The following is a description of a gene set: studied in species Mus musculus Any process that modulates the frequency, rate, or extent of the self-propelled movement of a cell or organism from one location to another in a behavioral context; the aspect of locomotory behavior having to do with movement. Mouse Gene Set: GOBP_REGULATION_OF_LOCOMOTION_INVOLVED_IN_LOCOMOTORY_BEHAVIOR, and this is the list of marker genes: Gria1, Drd2, Gla, Vps35, Dbn1, Arrdc3, Mecp2, Drd3, Ghsr